Given this list of marker genes RSF1, WNT3A, SCN2B, HDGF, KNCN, PRRC2C, LAMC1, CD2, PADI2, SYNPO2L, FGF6, PAX2, RCC2, CHD4, AGO1, TNKS1BP1, SWAP70, BBOX1, PAQR6, VAX1, CDKN2C, LOXL4, PRRG4, SLF2, GDPD4, FXYD6, UBXN10, PRRX1, TMPRSS4, CTTNBP2NL, PTPRJ, PPFIA1, PTMS, CRYAB, RAB18, SAAL1, EGR2, ABCG4, ITGB1, MCAM, PRDM16, VANGL1, CAVIN3, SH3BGRL3, EPC1, RAB30, LMNA, SKIDA1, RNF2, PRKAA2, KISS1, TNNI3K, USP5, CELF3, MADD, TSPAN9, GATA3, PPP2R1B, ACTA1, TLX1, MYPN, TIMM23, TMEM86A, RTN4RL2, NFKB2, HSPB2, MUC1, LRRN4CL, BCL9L, ELF3, RAPSN, CDC42SE1, TMEM125, AAMDC, CNNM2, POLD4, CCND2, PEA15, SHC1, ADIPOR1, ANKRD1, NOTCH2NLA, CWC15 (CWC15 spliceosome associated protein homolog), EPHB2, BDNF, LMOD1, ANXA8, WBP1L, NPPB, LINC01164, CDC14A, AVPI1, LIN28A, NOTCH2, PDZK1IP1, MTX1, IL18BP, MRGPRF, CDCA3, PIAS3, RNF207, USP2, SGIP1, MDK, DENND2B, SLC1A7, OVOL1, HOOK1, MLLT11, ATP1B1, PBX1, MAST2, CACNA1S, TIAL1, OTUD7B, TNNT2, NES, FAM53B, IPO13, HMGN2, RBM14, MAPKAPK2, PGAP2, EHD1, TRIM63, PBXIP1, SLC6A9, NEXN-AS1, CKS1B, LHX4, BRCA2, SLC6A13, ZMIZ1, SRRM1, ADD3, SYTL2, EPHA2, DEDD, RSC1A1, MTF2, RTN3 (NCBI Gene Id 95608), CCSER2, FIBIN, CUL2, PTPRCAP, CLC, DPM3, FRMD4A, CCDC18, OR10A5, DENND1B, RASGRP2 (NCBI Gene Id 10235), C10orf71, RASAL2, TENT5B, PRUNE1, KCNIP2, IER5, DR1, CEND1, CYP26A1, PDZD8, JAM3, SIPA1, ZC3H11A, DNM3, VCL, CHKA, PPA1, SYT2, CPT1A, ATPAF1, TINAGL1, CNN3, ARHGAP29, PLEKHN1, KDM5A, ZNF384, ELAVL4, KDM4D, LAMB3, ANK3, NID1, PRMT3, NKAPD1, ZNF485, SLC17A6, SLK, KIRREL3, OLFML3, MFAP5, NECTIN1 (NCBI Gene Id 84853), ZBTB37, SYT8, POGK, TOR1AIP2, SLC39A13, CCN1, DAB1, JMJD1C, FOLR1, THBS3, LRRC32, OVGP1, MAN1A2, CGN, MPZ, EPS8L2, BRMS1, FGFR2, PTPRF, ETV3, C1orf21, ARID1A, LAMC2, SCNN1A, NNMT, POGZ, CNIH2, DLG2, CA14, SDCCAG8, KIF1B, TMSB4XP1, SZRD1, CACNA1E, C1orf116, here is a description of the gene set: Genes having at least one occurrence of the motif GRRATG in the regions spanning 4 kb centered on their transcription starting sites. This matches the transcription factor binding site V$TEF1_Q6 (v7.4 TRANSFAC). Human Gene Set: TEF1_Q6 species: Homo sapiens